The following is a description of a gene set: Mouse Gene Set: GOBP_REGULATION_OF_MICROTUBULE_POLYMERIZATION_OR_DEPOLYMERIZATION Any process that modulates the frequency, rate or extent of microtubule polymerization or depolymerization by the addition or removal of tubulin heterodimers from a microtubule. studied in species Mus musculus, and this is the list of marker genes: Fes, Cav1, Mid1ip1, Slain1, Snca, Mecp2 (methyl CpG binding protein 2), Gas2l1, Pde4dip, Hspa1a, Apc2, Tbcd, Cdkn1b, Mapre1, Mapt, Stmn4, Nme7, Camsap2, Stmnd1, Nav3, Hdgfl3, Tpx2, Map6d1, Mapre3, Gda, Met, Stmn1, Ska2, Ska1 (spindle and kinetochore associated complex subunit 1), Diaph3, Ska3, Aurkb, Cav3, Ankrd53, Specc1l (sperm antigen with calponin homology and coiled-coil domains 1-like), Stmn3 (NCBI Gene Id 99032), Clasp1 (CLIP associating protein 1), Map1s, Clasp2, Kif21a, Slain2, Clip3, Apc, Bmerb1, Arl2, Ckap5, Dyrk1a, Eml2, Hdac6, Camsap1, Htr1a, Spef1, Abl1, Taok1, Atxn7, Eml4, Sgk1, Map2, Rps3, Map1b, Drg1 (developmentally regulated GTP binding protein 1), Tubb4a, Cdh5, Prune1, Git1, Arhgef7, Gba2, Wdr47, Fkbp4, Ckap2, Cdk5rap2, Psrc1, Ttbk2, Bbof1, Trim54, Gas2l2, Fgf13, Trpv4, Rp1 (NCBI Gene Id 19888), Rac1, Spast, Numa1, Slc39a12, Arhgef2, Akap9, Stmn2, Clip1, Camsap3, Pak1, Mapre2, Inpp5j, Hspa1b, Ccdc88c, Dctn1, Mid1, Map1a, Togaram1, Mapk8, Cib1, Katnb1